Given this list of marker genes PLXND1, CHRNA1, MYMX, MYMK, CHRND, LMX1B, TRPV4, REV3L, ITPR1, CHRNG, TBX5, TBX3, here is a description of the gene set: species: Homo sapiens Absence of the musculature. Aplasia of the musculature Human Gene Set: HP_APLASIA_OF_THE_MUSCULATURE